The following is a description of a gene set: studied in species Homo sapiens Human Gene Set: GOBP_ALPHA_BETA_T_CELL_DIFFERENTIATION The process in which a precursor cell type acquires the specialized features of an alpha-beta T cell. An alpha-beta T cell is a T cell that expresses an alpha-beta T cell receptor complex., and this is the list of marker genes: SLAMF6, MTOR, ITPKB, ENTPD7, ADA, RSAD2, MYB, GLI3, RC3H2, SOCS5, GPR18, AP3B1, MIR21, BCL3, HLX, FUT7, PDP2, CBFB, NLRP3, ARMC5 (armadillo repeat containing 5), HLA-DRB1 (NCBI Gene Id 730415), CD83, SOCS3, NKX2-3 (NK2 homeobox 3), BRD2, IHH, IL27, IL6R, RELB, TOX, RC3H1, PSMB11, IRF4, SYK, NKAP, CCL19, SLC4A2, RUNX3, IL2, MEN1, STAT4, TBX21, IL23A, CRACR2A, LY9, IL23R, SHB, KLHL25, RARA, STAT6 (NCBI Gene Id 6778), BCL11B, ICOS, IL12B (interleukin 12B), LILRB4, BRD4, SOCS1, ZC3H12A, TGFBR2, FOSL2, PLA2G2D, ITK, RPL22, HLA-DRA (major histocompatibility complex, class II, DR alpha), ZNF683, ABL1, PIK3R1, BATF, JAK1, BCL2, ANXA1, TMEM98, IL2RG, RHOA, PNP, ATF2, GATA3, IL18, TNFSF18, ATP7A, KMT2A, IRF1, IL6, RORA, ZAP70, AP3D1, STAT5A, CTSL, IFNG, ZBTB16, JUNB, ZFPM1, MALT1, PTCRA, BCL6, EOMES, PRKCZ, NFKBIZ, IL12RB1, SEMA4A, BRAF, GPR183, FOXP3, SASH3 (SAM and SH3 domain containing 3), IL21, LEF1, IL18R1, CD80, NFKBID, IL6ST, JAK3, IL4R, FOXP1, HMGB1, PTGER4, CD86, OPA1 (OPA1 mitochondrial dynamin like GTPase), GPR65, SPN, RORC, STAT3, EP300, TNFSF8, ZBTB7B, LOXL3, LGALS1, SMAD7, CD69, ASCL2, PRDM1, SH3RF1, SHH, ICOSLG, TNFSF4, RIPK2, RUNX1, PRR7, KCNK18, LGALS9, NCKAP1L, TBK1